The following is a description of a gene set: studied in species Homo sapiens Beta-oxidation of pristanoyl-CoA Human Gene Set: REACTOME_BETA_OXIDATION_OF_PRISTANOYL_COA, and this is the list of marker genes: ACOT8, AMACR, ACOXL, HSD17B4, SCP2, ACOX3, CRAT, CROT, ACOX2